The following is a description of a gene set: Human Gene Set: GOBP_POSITIVE_REGULATION_OF_PROTEIN_TYROSINE_KINASE_ACTIVITY studied in species Homo sapiens Any process that increases the rate, frequency, or extent of protein tyrosine kinase activity., and this is the list of marker genes: CSF1R, PTPN1, ABI1, SRCIN1, NEDD9, DOK7, GPRC5B, ADAM17, LILRA5, CASS4, UNC119